Given this list of marker genes AREG, BEX3, TLE3, ERBB3, RIPOR2, GRHL2, CEMIP2, EHF, RPS10, ALDOC, DUSP6, CNN1, KRT14, PAWR, ANO1 (anoctamin 1), MUC15, TNC, LCN2, ENAH, SLPI, SPP1, GDPD1, THBS1, PFN2, ESRP2 (epithelial splicing regulatory protein 2), CLDN4, C1orf210, TGFB3, WNT2, SLCO2A1, TMEM30B, SFXN3, MARCKSL1, TASOR2, SDC4, CLCA3P, AQP5, SPON2, GAS1, CNN3, ATP1A1, CYB561, TIMP1, NFKB2, SFRP1, VASN, BEX1, CSN3, GALNT3 (NCBI Gene Id 2591), ALDH1A1, SLC44A2, KRT8, FBLN7 (fibulin 7), MBOAT1, POF1B, RPL37A, HEY1, FXYD3, FOXA1, SCIN, DPYSL3 (NCBI Gene Id 54406), SERPINB11, SHROOM3, FOLR1, SOX4, PLAC8, TGIF1, CDH1, ATP1A3, FXYD2, CLDN3 (claudin 3), TGM2 (NCBI Gene Id 7052), EZR, FGFR2, ID4, IRX3, CAPG, BCL6, KIF22, IGFBP2 (insulin like growth factor binding protein 2), ACTA2, MFGE8, PDLIM2, ABCC3, PROM1, CNTN1, UPK3A, RIPK4, WFDC2, VWF, F3, IMPDH2, SDC1, ARG2, CLDN10, KRT7, ERRFI1 (NCBI Gene Id 54206), MYB, THBS2, PDLIM4, CALD1, CSN1S2AP, SPINT1, PERP, MARK1, STC2, TMEM40, COL16A1, FAAP20 (FA core complex associated protein 20), COL9A1, TNFAIP6, CHI3L1, RPL22, INMT, TNFAIP2, HDAC11, ADAMTS5, MDK, CTSE, MKRN1, FIGN, PADI2, IRX5, RBP1, PTPRK, GZMA, SESN3, LAD1, NFIL3, IGFBP6, BECN1, CSN2 (NCBI Gene Id 1447), WWC1, PIAS3, PLPP2, IRF6, RNF128, PRLR, PLEKHB1, MMD2, SPON1, ID2, PREB, ELF5, ELAPOR1, JPT1 (NCBI Gene Id 51155), ACTG2 (NCBI Gene Id 72), PLET1, KRT19, FEN1, PDZK1IP1, CLDN8, RAB17, PLAT, CDH11, ICE1, FIP1L1, CD14, TMED3, RAB7B, PATJ, GIPC2, SERPINB5, IRX1, ATP2C1, COL7A1, TRMT1, EMB, JUN, ARHGEF3, HLA-DRB1, SLC2A1, TUBA4A, FHDC1, RETREG1, BSPRY (B-box and SPRY domain containing), IKBIP, CSN1S1 (NCBI Gene Id 1446), TLCD4, ISYNA1, COTL1, CAP1, PLK2, TEAD2, TPBG, WDR43, MANSC1, TMPRSS2, PROM2, PTX3, TTPA, ESRP1, PTN, EPB41L4B, HSPA1B, GATA3, TMEM158, STARD10, NHSL1, CXCL14, ACOT1, KRT18, ZNF704, EGR2, CD9, MAFB (MAF bZIP transcription factor B), DDR1, CD24, CEACAM1, ARHGAP21, TACSTD2, APOD, SOX9, F2R, CRACR2B, BOC, STAMBPL1, NXN, FN1, DKK3, CDCP1, ATP6V1B1, SPNS2, TSPAN8, RPL36A, TFAP2C, IRX2, IRAK1, ZBTB8A, ACOT2, OCLN, TNFRSF12A, CCK, VCAN (NCBI Gene Id 7902), TXNDC16, CITED1, ATP5IF1, LTF, TRPS1, LY6D, GAS6, CPT1A, RPL5, PLA2G7 (NCBI Gene Id 7941), CYSTM1, KCNK1, RND3, SYNPO, SAT1, RUNX1, EPCAM, DUSP16, TP63, BTN1A1, PALLD, FZD6, RAB25, KLF5, NPR3, IL33, HTRA1, CLDN7, LALBA (NCBI Gene Id 3906), HEBP2, ST14, FBXO32, INHBB, SLC39A6 (solute carrier family 39 member 6), DSP, FOS, here is a description of the gene set: Human Gene Set: MCBRYAN_PUBERTAL_BREAST_4_5WK_UP Genes up-regulated during pubertal mammary gland development between week 4 and 5. species: Mus musculus from publication McBryan J, Howlin J, Kenny PA, Shioda T, Martin F (PMID 17486082) Expression microarray analysis identified over genes regulated during puberty in the mouse mammary gland. Most prominent were genes whose expression increased in parallel with pubertal development and remained high thereafter. Members of the Wnt, transforming growth factor-beta and oestrogen-signalling pathways were significantly overrepresented. Comparison to expression data from CITED1 knockout mice identified a subset of oestrogen-responsive genes displaying altered expression in the absence of CITED1. Included in this subset are stanniocalcin2 (Stc2) and amphiregulin (Areg). Chromatin immunoprecipitation revealed that ERalpha binds to oestrogen response elements in both the Stc2 and Areg genes in the mammary gland during puberty. Additionally, CITED1 and ERalpha localize to the same epithelial cells of the pubertal mammary gland, supporting a role for interaction of these two proteins during normal development. In a human breast cancer data set, expression of Stc2, Areg and CITED1 parallel that of ERalpha. Similar to ERalpha, CITED1 expression correlates with good outcome in breast cancer, implying that potential maintenance of the ERalpha-CITED1 co-regulated signalling pathway in breast tumours can indicate good prognosis.